The following is a description of a gene set: Human Gene Set: GOBP_RESPONSE_TO_INTERLEUKIN_9 Any process that results in a change in state or activity of a cell or an organism (in terms of movement, secretion, enzyme production, gene expression, etc.) as a result of an interleukin-9 stimulus. studied in species Homo sapiens, and this is the list of marker genes: JAK3 (NCBI Gene Id 3718), STAT3, IL9, JAK1 (Janus kinase 1), CITED1, STAT1, IL9R, IL2RG, STAT5A